Given this list of marker genes FYB1 (NCBI Gene Id 55458), PSMD11, UBB, PIK3CA, PDPK1, UBE2N, WAS, TRAF6, PSMD12, GRAP2, PAK3, EVL, PIK3CB, HLA-DQB2, NFKBIA, BTRC, HLA-DRB3, PSMC3, RPS27A, LCK, HLA-DQB1, LAT, PSMC1, PLCG1, PSMD14, PTEN, TAB2, MALT1, PSMB4, HLA-DRB1, PIK3R1, TRBC1 (NCBI Gene Id 28639), UBC, CD4, CD3D, HLA-DPB1, PSMD7, PSMB6, CD247, PRKCQ, TRAV29DV5, UBA52, HLA-DRA, PAK1 (NCBI Gene Id 5058), FBXW11, TRAV19, PSMA2, NFKB1, TRAV8-4, PSMB5, PSMD6, PSMA7, VASP, HLA-DRB4 (NCBI Gene Id 3126), PTPRJ, PSMD8, CD101, HLA-DQA1, SKP1, HLA-DQA2, CHUK, PLCG2, PSMD13, IKBKB, PSMC2, PSMA1, PAK2, PSMB2, TRAC, MAP3K7, TRBV7-9, PSMD2, HLA-DRB5, PSMD1, INPP5D, PIK3R2, PSMB7, CD3E, CSK, UBE2D1, UBE2V1, NCK1, ADRM1, ITK, PSMA4 (proteasome 20S subunit alpha 4), PTPN22, BCL10, CD3G, TRAT1, PTPRC, PAG1, ENAH, RIPK2, PSMC4, ZAP70, PSMB3 (proteasome 20S subunit beta 3), HLA-DPA1, CUL1, LCP2, PSMA5, CDC34, IKBKG, PSMD3, RELA, PSMC5, PSMC6, TRBV12-3, SEM1, PSMA3, PSMA6, PSMB1, CARD11, UBE2D2 (NCBI Gene Id 7322), here is a description of the gene set: Reactome Pathway: TCR signaling part of: Adaptive Immune System The TCR is a multisubunit complex that consists of clonotypic alpha/beta chains noncovalently associated with the invariant CD3 delta/epsilon/gamma and TCR zeta chains. T cell activation by antigen presenting cells (APCs) results in the activation of protein tyrosine kinases (PTKs) that associate with CD3 and TCR zeta subunits and the co-receptor CD4. Members of the Src kinases (Lck), Syk kinases (ZAP-70), Tec (Itk) and Csk families of nonreceptor PTKs play a crucial role in T cell activation. Activation of PTKs following TCR engagement results in the recruitment and tyrosine phosphorylation of enzymes such as phospholipase C gamma1 and Vav as well as critical adaptor proteins such as LAT, SLP-76 and Gads. These proximal activation leads to reorganization of the cytoskeleton as well as transcription activation of multiple genes leading to T lymphocyte proliferation, differentiation and/or effector function. species: Homo sapiens